The following is a description of a gene set: A protein activation cascade that contributes to blood coagulation and consists of the interactions among high molecular weight kininogen, prekallikrein, and factor XII that lead to the activation of clotting factor X. Mouse Gene Set: GOBP_BLOOD_COAGULATION_INTRINSIC_PATHWAY species: Mus musculus, and this is the list of marker genes: Apoh, F8, Gp1ba, Gp9, Gp5, Flna, Gp1bb